The following is a description of a gene set: Human Gene Set: GOBP_POSITIVE_REGULATION_OF_CALCIUM_MEDIATED_SIGNALING Any process that activates or increases the frequency, rate or extent of calcium-mediated signaling. studied in species Homo sapiens, and this is the list of marker genes: SYK, IAPP, PPP3R1, EDN2 (NCBI Gene Id 1907), HTT, PTPRC, PTPRJ, CD4, CCL4 (NCBI Gene Id 6351), P2RX3, HINT1, NMUR2, C10orf71, TRAT1, P2RX5, P2RX4 (NCBI Gene Id 5025), NMUR1, CIB1, LMCD1, NEGR1, IGF1, CAMTA1, CLEC7A, CALCR, NEUROD2, GPR62, TREM2, PLCG2, CD3E, PTBP1 (polypyrimidine tract binding protein 1), RAMP3, PDGFRB, PPP3R2, LACRT, AKAP5, TNF, CA8, SPPL3, PDGFRA, PRNP, EDN1, P2RX2, AKAP6, PRKACA (protein kinase cAMP-activated catalytic subunit alpha), PCP4, PPP3CC, ERBB3, APP, CCL3, HTR2C, GRM5, ADA, SLC9A1, CDH13, ZAP70 (NCBI Gene Id 7535), CHP2, PPP3CA, CHERP, PPP3CB